Given this list of marker genes H2BC17, H2BC1, H2BC15 (NCBI Gene Id 8341), H3C1, H4C9, H3C2 (H3 clustered histone 2), H2AX, H3C10, H2BC26, H4C6, H2AC7, MCPH1, H4C16, H3C7, H3-3A, H4C12, PHF8, H4C15, H2BC9, H2AC6, H2AC14, H4C14, NCAPH2, H4C1, H4C11, H2BC21, H2BC6, H4C8, H2AC19, CDK1, H2BC4 (NCBI Gene Id 8347), H2BC3 (NCBI Gene Id 3018), H3C13, H3C11, H2BC8, SMC4, CCNB1, H2AC8, SMC2, NCAPG2, SET, PLK1, H2AB1, H2BC13, H3C8, H2AC20, H2BC12L, H3-3B, H2AZ2, NCAPD3, H2BC12, H4C13, H3C6, KMT5A, H2AJ, H3C3 (H3 clustered histone 3), H2BC14, H4C4, H2BC10, H3C12, H2BC7, H2AC18, H4C3, H2BC5, H2AC4, H4C5, H3-4, RB1, H4C2, H3C4, H3C14, H3C15, H2BC11, here is a description of the gene set: Condensation of Prophase Chromosomes studied in species Homo sapiens Human Gene Set: REACTOME_CONDENSATION_OF_PROPHASE_CHROMOSOMES